Given this list of marker genes Nr0b1, Plekha1, Sf1, Tmf1, Dhh, Pdgfra, Nr5a1, Ar, Amh, Sgpl1, Ccnd1, Nkx2-1, Map7, here is a description of the gene set: The process in which a relatively unspecialized cell acquires specialized structural and/or functional features of a Leydig cell. A Leydig cell is a testosterone-secreting cell in the interstitial area, between the seminiferous tubules, in the testis. Mouse Gene Set: GOBP_LEYDIG_CELL_DIFFERENTIATION species: Mus musculus